Given this list of marker genes Ppm1k, Clstn1, Scrg1, Kif5c, Mllt3, Sh3bp5, Eif4g3, Urm1, Traf1, Klhl26, Cry2, Fuca1, Rps6ka1, Thap3, Ly6d, Bbox1, Ago4, Ndufs5, Crip2, Epc2, Peli2, Thbs4, Sncg, Arhgef6, Ppp1r8, Irak2, Ltbp2, Ces1f, Enho, Sap30, Necap2, Rims3, Tab2, Epb41, Gabpb1, Leng9, Rhou, Proser2, Zmpste24, Phyh, Ifih1, Samhd1, Bspry, Lhfpl6, Srsf4, Herpud1, Golga2, Padi2, Glcci1, Scp2, Tspan7, Klhdc7a, Rorc, Mib1, Arhgef3 (Rho guanine nucleotide exchange factor 3), Usp48, Ube4b, 4931406C07Rik, Slc16a6, Setd5, Prpf38a, Zfyve9, Mmachc, Smad3, Rigi, Itm2c, Plb1, Paqr7, Dph2, Surf4, Fam76a, Txnip, Rsad2, Cdc42ep3, Tmem182, Errfi1, Fhip1a, Ncoa3, Syt13, Pink1, Madd, Pkn2, Mul1, Tnnt3, Svbp (small vasohibin binding protein), Rpl22, Sdc2, Cdc40, Acbd5, Hsph1, Ago1 (NCBI Gene Id 286948), Per2, Enah, Reep5, Mrto4, Cfb, Ppm1b, Elovl1, Cavin1, S100pbp, Trp53inp1, Cds2, Syce1, Tmem59, Usp20, Psmb2, Tmem82, Ldlrad3, Cpt2, Scarf1, Cdhr1, Tsc22d3, Blnk, Cxcl12, Afap1l1, Slc7a10, Nhsl3 (NCBI Gene Id 97130), Vpreb1a, Chn2, Gdpd3, Cited4, Dhdds, Cfap410, Prdx6, Grid2 (NCBI Gene Id 94324), Pum1, Tob1, Kdf1, Atp5if1, Zfp770, Fam13a, Zfp395, Ppcs, Ebna1bp2, Efhd1, Slc6a2, Tor3a, Itm2b, Serinc3, Fem1c, Ppm1l, Dusp16, Garem1, Fabp4, Epb41l1, Pef1, Mapk8ip1, Emc1, Nnmt, Chmp4b, Rabep2, Ddost, Rcc2, Mga, Cutal, Rxra, Lin7c, Mknk2, Rpa2, Kpna6, Sult1a1, Tmem54, Upf2, Pcdhb22, Cacfd1, Cflar, Cfd, Smcr8, Slc22a4, Sp110, Casz1, Ggt6, Plin4, Txlna, Plekhf1, Rragc (Ras-related GTP binding C), Cdo1, Pm20d1, Oas2 (2'-5' oligoadenylate synthetase 2), Tmtc2, Vdr, Galnt12, Car3 (carbonic anhydrase 3), Dhrs1, Sp100, Rbp4, Tmem35b, Rbm39, Sgcb, Inpp5b, Bsdc1, Lypla2, Duoxa1, Slc23a2, Cox8b, Smim12, Adipoq (NCBI Gene Id 11450), Ppfibp2, Fam20a (NCBI Gene Id 208659), Cidec, Mtfr1l, Selenoi (NCBI Gene Id 97239), Ddhd2, Dnajc8, Tob2, Alcam (activated leukocyte cell adhesion molecule), Gdpd1, Eif4e3, Zbtb43, Smoc2, Mbp, Aoc3, Bdh1 (3-hydroxybutyrate dehydrogenase, type 1), Klf15 (NCBI Gene Id 66277), Acsl1, Ttc9, Lrrc42 (leucine rich repeat containing 42), Tcf12, Uqcrh, Entpd2, Ccdc28b, Grtp1, Zbtb8os, Prickle2 (NCBI Gene Id 77894), Amy1, Ddo, Lalba, Slc25a29, Epha2, Daam1, Foxred2, Btg1, Phactr1, Ddi2, Gbp9, Tcf4 (NCBI Gene Id 67762), Dppa1, Arfrp1, Cst3, Spint2, Micos10, G0s2, Nfic, Wfdc21, Hp1bp3 (heterochromatin protein 1, binding protein 3), Iqcc, Notch1, Urod, C5ar2, Mindy2, Retnla (resistin like alpha), Hey1, Aifm2, Ski, Gpc4, Grk2, Zbtb40, Ak2, Bach2, Lrrc1, Asic1 (acid-sensing ion channel 1), Acad9, Nmnat1, Cbx7, Trim24, Fosl2 (fos-like antigen 2), Dedd2, here is a description of the gene set: species: Mus musculus Down-regulated genes in breast tumors from transgenic mice overexpressing ERBB2 and CDC25A compared to those from mice overexpressing ERBB2 only. from publication Ray D, Terao Y, Fuhrken PG, Ma ZQ, DeMayo FJ, Christov K, Heerema NA, Franks R, Tsai SY, Papoutsakis ET, Kiyokawa H (PMID 17283130) Checkpoint pathways help cells maintain genomic integrity, delaying cell cycle progression in response to various risks of fidelity, such as genotoxic stresses, compromised DNA replication, and impaired spindle control. Cancer cells frequently exhibit genomic instability, and recent studies showed that checkpoint pathways are likely to serve as a tumor-suppressive barrier in vivo. The cell cycle-promoting phosphatase CDC25A is an activator of cyclin-dependent kinases and one of the downstream targets for the CHK1-mediated checkpoint pathway. Whereas CDC25A overexpression is observed in various human cancer tissues, it has not been determined whether deregulated CDC25A expression triggers or promotes tumorigenesis in vivo. Here, we show that transgenic expression of CDC25A cooperates markedly with oncogenic ras or neu in murine mammary tumorigenesis. MMTV-CDC25A transgenic mice exhibit alveolar hyperplasia in the mammary tissue but do not develop spontaneous mammary tumors. The MMTV-CDC25A transgene markedly shortens latency of tumorigenesis in MMTV-ras mice. The MMTV-CDC25A transgene also accelerates tumor growth in MMTV-neu mice with apparent cell cycle miscoordination. CDC25A-overexpressing tumors, which invade more aggressively, exhibit various chromosomal aberrations on fragile regions, including the mouse counterpart of human 1p31-36, according to array-based comparative genomic hybridization and karyotyping. The chromosomal aberrations account for substantial changes in gene expression profile rendered by transgenic expression of CDC25A, including down-regulation of Trp73. These data indicate that deregulated control of cellular CDC25A levels leads to in vivo genomic instability, which cooperates with the neu-ras oncogenic pathway in mammary tumorigenesis. Mouse Gene Set: RAY_TUMORIGENESIS_BY_ERBB2_CDC25A_DN